Given this list of marker genes DDX28, NLN, JCHAIN (NCBI Gene Id 3512), C4orf17, TMOD2, MFSD14A, IL12RB1, EMP3, MUTYH, DPH7, RORA, LINS1, MRPL15, PNKP, GPN2, UQCRFS1, NUP62, TLE5, RIOX2, IFITM10, DTD1 (D-aminoacyl-tRNA deacylase 1), CREBZF, CFL1, RAB29, CBX7, BRD9, SACM1L, GALE, PPP2R5C, GLO1, ABCF1, TICRR, APC, RAC1, IPMK, MCMBP, ZNHIT2, RNPEP, ACTG1, ANXA6, OSBPL3, ASNSD1, ALAD, SERAC1, SDR39U1, RIOK3, GSR, MTERF2, DUS4L, TEKTIP1, TSC22D1, ANKRD54, PSMA4, PAXIP1, UNC119B, AVL9, OSTM1, MYL4, SAP30BP, ZNF658, TBCB, TKT, ATP8B2, NIPSNAP1, CD36, VTI1A (vesicle transport through interaction with t-SNAREs 1A), NEPRO, OSBP, RABEPK (NCBI Gene Id 10244), FMC1, NIF3L1, MPC1, PARK7, KCNK5, PRXL2C, ANAPC16, TAGLN2, SLC30A9, MYO7A, MIR22HG, CARD11, CA5B, MTMR14, VDAC3, ABCE1, SQLE, CCL5, ZFTA, PILRA, ETV3, ETV6, DERL3, PACS2, PIWIL2, OTP, CIPC, KTI12, IL18RAP, EIF2B1, HMMR, GSAP, GLUD1, TMEM177, CRIP2, SMN1, H2AZ1 (H2A.Z variant histone 1), KLRD1, SPICE1, C18orf21, LCA5, TWF2, H2AX, TOM1, SNAPC4, CAT, UROD, KCNAB2, GNA15, NIBAN3, NSDHL, CENPM, XRN2, GAB3, AMPD2, UBALD2, STX11, MOSPD2, STOML2, TMEM268, BLVRB, CMTR2, MMUT, PRKRIP1, VPS33B, KPTN, PPP3CA, CXCR3, KRAS, USP15, AIMP2, COX18, RPS27L, TAOK3, STOM, OTULIN, GRAMD2B, TMEM167A, FIBP, TPST2, HLCS, MSMO1 (NCBI Gene Id 6307), TXNIP, COPS5, CCNE1, EIF4E, RPS25, PSMD13, CNDP2, TWF1, AZI2, PCNP, IFI30, FBXO3, LAMB3, ENTPD5, UBE2N, EFHD2, CDYL2, POLK, SREBF2, CFAP221, RAB3GAP2, PRKAR2A, SLPI, GPATCH1, WRN, RASGRP2, F2R, PHETA2 (PH domain containing endocytic trafficking adaptor 2), HBB, UCHL1, RNF7, FAM91A1 (family with sequence similarity 91 member A1), CITED2, ADD3, UCK1, WASHC5, MFSD2A, TFB2M, MTPN, CCNQ, PKIG, C6orf136, RABIF, GCAT, CC2D1B, ZIK1, ARPC1B, COMMD6 (COMM domain containing 6), SIT1, here is a description of the gene set: STAT3, an essential transcription factor with pleiotropic functions, plays critical roles in the pathogenesis of autoimmunity. Despite recent data linking STAT3 with inflammatory bowel disease, exactly how it contributes to chronic intestinal inflammation is not known. Using a T cell transfer model of colitis we found that STAT3 expression in T cells was essential for the induction of both colitis and systemic inflammation. STAT3 was critical in modulating the balance of T helper 17 (Th17) and regulatory T (Treg) cells, as well as in promoting CD4+ T cell proliferation. We used chromatin immunoprecipitation and massive parallel sequencing (ChIP-Seq) to define the genome-wide targets of STAT3 in CD4+ T cells. We found that STAT3 bound to multiple genes involved in Th17 cell differentiation, cell activation, proliferation and survival, regulating both expression and epigenetic modifications. Thus, STAT3 orchestrates multiple critical aspects of T cell function in inflammation and homeostasis. species: Homo sapiens Genes up-regulated in CD4 T cells treated with TGF beta and IL6: STAT3 knockout versus wildtype. Human Gene Set: GSE21670_STAT3_KO_VS_WT_CD4_TCELL_TGFB_IL6_TREATED_UP from publication Durant L, Watford WT, Ramos HL, Laurence A, Vahedi G, Wei L, Takahashi H, Sun HW, Kanno Y, Powrie F, O'Shea JJ (PMID 20493732)